The following is a description of a gene set: Human Gene Set: MIR6124 species: Homo sapiens from publication Chen Y, Wang X (PMID 31504780) Genes predicted to be targets of miRBase v22 microRNA hsa-miR-6124 in miRDB v6.0 with MirTarget v4 prediction scores > 80 (high confidence targets)., and this is the list of marker genes: FOXN3, BLOC1S2, PAPSS1, TSPYL6, FOXP1, MKRN1, CNR1, ADAM12, ZNF626, NAMPT, ELAVL1, LAMA3, RANBP1, BMPR2, TEAD1, DYNC2LI1, YPEL5, ZNF507 (NCBI Gene Id 22847), TAFA1, ELK3, INHBB, RAB6B (NCBI Gene Id 51560), ZDHHC9, MAGI2, ZNF561, OR9Q1, GMNC, ARHGAP42, ZNF521, CTCF, WNK3, RNF128, SETD9, PARP9, MGAT2 (alpha-1,6-mannosyl-glycoprotein 2-beta-N-acetylglucosaminyltransferase), SF1, DLL1, GRIN2A, ATG14, IDS, SEC62, KIAA0408, PAG1, REEP3, SUMF1, CDK17, FREM2, HAMP, GTF3C4, TRERF1 (transcriptional regulating factor 1), IMPA1, OAZ2, TMEM158, FGD4, NR1D2, CFAP107, TACC1, HYOU1, TFAP2A, SOX6, COL11A1 (collagen type XI alpha 1 chain), RAB23, ZNF704, PTPRB, STXBP5, IRS1, KLF12, TMED2, MIB1, SLC32A1, GFRA1, KAT6A, SLC4A8, ZFP36L1, STX16, ZEB2, LRRC39, ENDOD1, TWNK, KMT2C, TENM1, RNF169, SPINK5, C11orf87, CSNK2A2 (casein kinase 2 alpha 2), CAST, CREBRF, ELFN1, PLK2, HECTD4, SLC30A4, PDIA4, LDB2, ARIH1, PLEKHM3, CLEC17A, KCNJ3, NFASC, GLS, USP7, CRIM1, BCL11B, LCOR, CDY1B, ESRRG, ACTA2, KCNJ2, OTUD7B, SLC6A14, MAP2, TMEM132B, ANGPTL7, DBN1, AGFG2, ANKRD17, MEGF10, ANGEL1, RSBN1L, AIPL1, ERRFI1 (ERBB receptor feedback inhibitor 1), GAS7, TTPAL, ATXN3, WASF1, TTLL5, LRRTM2, B4GALT1, MFAP3L, CTLA4, XIRP2, ARHGEF38, MEF2C, DTNA, PSD3 (NCBI Gene Id 55358), DCBLD2, A1CF, BCL11A, MFAP1, MARCKSL1, FAM50A, XPO4, BCCIP, TSC22D1, CAV2, SS18, ASH1L, CIAO1, OVGP1, MORC3, SLC25A12, TUBA1B, PTBP2, C9orf72, RIN2, POLH, NAA30, DNAJC11, GRIN3A, API5, PFKFB2 (NCBI Gene Id 5208), POU2F2, EPC2, POGLUT3, MBOAT4 (membrane bound O-acyltransferase domain containing 4), HNRNPA2B1, CHIC1, ARPC2, G3BP2, CXCL13, CCDC47, DACH1 (dachshund family transcription factor 1), KLF6, KSR2, RIPOR2, DCN, SLC25A24, STAM, ZMYM2, SAMD12, CASQ2, KLF8, ACBD6, ETV1, RARB, KCTD18, PCDH19, NSL1, ESPNL, POF1B, ZNF407 (NCBI Gene Id 79610), C16orf46, STAT1, CRACDL, MTMR3, SHANK2, GPBP1L1 (NCBI Gene Id 60313), NEDD4L, COX15, TMC7, ACIN1, APOB, C5orf46, HNRNPK, P2RY13, UFD1, RASL11B, UBE4B, SGPL1 (sphingosine-1-phosphate lyase 1), MINDY2, ARID4B, ZSCAN25, MYOCD, PDE10A, CD209, PRTG, SPIRE1, TNFSF10, IFT81, ABLIM1 (NCBI Gene Id 3983), FOXN2, COPS2, PPM1L, BRD8, CD80, HIGD1A, MTF1, RC3H1, CWC25, SERPINH1, TXNDC17, LIN7A, SEMA3E, LRRTM3, MAFK, TREM1, MAP3K2, ETS1, PTPRN2, BAG5 (BAG cochaperone 5), METTL8, BEST3, IL1R1, ZNF609, MAPK1, ZMAT3, XPR1, ADAMTS17, ILDR2, COL19A1, TAF12, TRIM6, SHC1, ZNF608, RAB30, BRWD3, MAN1C1, ZNF398, NXT2, KIF3C, HUNK, STT3B, NSD1, SLC39A10, RAPGEF5, MAPRE3, OSBPL9, TUT4, GRM6, HAO1, KCNG3, PAK2, CLSTN1, KIF5B, HGSNAT, CDK14, MTHFD2, ZC3H12C, MAGI1, TMTC1, KPNA1, SRL, CASP14, RASGEF1B, ADAMTS5, SESTD1, AFF4, UBN2, INPP5E, ZNF365, OTUD7A, BCLAF3, PTCHD4, PRR27, BCAT1, FER, MBTD1, GLRB, CREB1, KDM5B, TAF5, MAPK10, MTCL3, MBOAT2, CBX1, MAP1B, RORA, GNB5, POC5, ANK3, NBN, TRPC5, EMX1, YWHAQ, ATXN1, FANCM, IL2RA, MOB1B, XYLT1, IST1, PECAM1, KLHDC10, CNOT6L, CALN1, PAPOLG, CASZ1 (castor zinc finger 1), GSTA1, DDO, C3orf70, ARFIP1, MYLK, GAL3ST3, ETFA, AKAP6, SP1, HSPA12A, EDEM3, PELI2, ONECUT2, ZNF280D, TMEM132C, PLPPR4, ACSL4, MYH10, COX10, SFT2D1, TAL1, PHRF1, KLF11, TANC2, ACTMAP, OPA1 (NCBI Gene Id 4976), SLCO2B1, RERE, ORMDL3, CEP350, CLSTN2 (calsyntenin 2), HLCS, MARF1, FKBP7, VAX1, INO80D, ERCC4, DENND1B, POU2F1, ABHD2, CFL2, DSC3, NEK11, SPATA4, ATP11C, VPS36, ZNF300, GLIPR1, PIP5K1A, CSGALNACT2, IPO11, KBTBD8, SPINK2, FZD6, RFX3, SH3TC2, KDM3B (lysine demethylase 3B), FOS, TMEM248, SPG21, RHOT1 (ras homolog family member T1), BAIAP2, OR51E1, CDYL2, BAZ2A, MSRB3, TMEM233, MINAR1, KCNJ15 (potassium inwardly rectifying channel subfamily J member 15), CDH12, DAG1, BHLHE40, PKP2, EIF2A, PAFAH1B2, PIK3CA, EPB41L1, RUFY2, TFF2, TAOK3, SIRT1, IGF1 (insulin like growth factor 1), ZBTB20 (zinc finger and BTB domain containing 20), TAF11, RABGAP1L, FAM120C, KIAA1210, EIF3A, ZMAT4, PTBP3, LTBP1, HOOK3, RPRD1B, LGI1, ANKIB1, CCDC6, CENPC, INSYN2A, TRIM5, PPP1R1A, AAK1, ELL2, OSBPL3, CREM, PHTF1, APBB2, ADAM22 (NCBI Gene Id 53616), CDY1, GIT2, BRWD1, HS3ST5, ITM2A, IRF2, DUOX2, GSTA2, INTS6, DHX57, MTX3, TKTL2, LINC00390, UBE4A, SCLT1 (sodium channel and clathrin linker 1), ZFAND5, CLINT1